Given this list of marker genes CACNA1D, HNF1A, OCA2, TMEM67, OTC, MPL (NCBI Gene Id 4352), SOX11, DNASE1, CDKN2C, HTT, ROS1, VAMP1, TNFAIP3, PLA2G6, INSR, IL12A, RFX7, LARP7, NLRP3, EZH2, LUZP1, AVPR2 (NCBI Gene Id 554, arginine vasopressin receptor 2), FIP1L1, POMC, CDC73, HESX1, IL23R, PTPN22, SYT2, ADNP, BLK, GLA, SRRM2, DZIP1L, IFT74, CDK13, PCSK1, SNAP25, SMARCB1 (NCBI Gene Id 6598), ABCC8, MN1, PACS1, FCGR2B, MC2R, KL, CD3D, PDCD1, PRKCZ, SYK, SIM1, SH2B1, SLC41A1, AVP, SATB2, CISD2, IL6, TNIP1, BRCA1, SLC1A3, NUMA1 (nuclear mitotic apparatus protein 1), SLC3A1, ATP1A3, KIAA0319L, OTX2, SLC4A1, SNORD115-1, MAPT, ERAP1, LEPR, SUPT16H, TXNRD2, MYT1L, KLRC4, PALB2, BRAF, TAF4, STAR, HLA-DRB1, YY1, CLDN16, PGM2L1, SOX3, IL10, GRN, AGPAT2, HLCS, SNRPN, ALPL, STAT3, SLC5A7, NTRK2, SMARCD1, CASR, SMARCC2, NKX2-1, MC4R, MEFV, COL13A1, KCNJ10, PAX4, STAT5B, SYNGAP1 (synaptic Ras GTPase activating protein 1), IRF2BP2, ATM, GPR101, CALR, NNT, RNU4-2, PWRN1, MAGEL2, IRF4, SPEN, NPHP1, TNFSF4, MMP23B, DPF2, PROKR2, P4HA2, STAT4, SLC2A3 (solute carrier family 2 member 3), ARID1B, ASXL1, BRCA2, HLA-B, NEK8, SPP1, UBE3A, HMGCL, ARID1A, CTNNB1, BCOR, BSND (barttin CLCNK type accessory subunit beta), IGHG1, AGRN, MEN1, AQP2, ACBD6, RARA, C4B, CTLA4, FLI1 (NCBI Gene Id 2313), TBL1XR1, PRKAR1A, ATP5F1B, CLDN10, PKHD1, CHAT, ACAT1, CDKN2B, NEXMIF, SKI (NCBI Gene Id 6497), ZNF699, PTPN3, SCARB2, ZSWIM6, PWAR1, FAS, IL12B, GRB10, ATRX, ETS1, ELP2, CTNS, RERE, SLC5A2, ITPR3, IFNGR1, TGFB1, HSD11B2, PALLD, GABRD, IRF5, ZBTB16, SMARCE1, SMARCA4, TLR4, ITGAM, PSEN1, NPM1, HSPG2, PDSS1, CASZ1, PML, TLR7, PREPL, SOX4, JAK2, SRSF2 (serine and arginine rich splicing factor 2), MAN1B1, BBS2, IRAK1, NAGS, UBAC2, CDKN1B, SLC46A1, PDPN, SLC12A3, ADCY3, ALMS1, WFS1, MEIS2, SMAD4, ASH1L (ASH1 like histone lysine methyltransferase), SLC25A1, TRANK1, CR2, KRAS, CRELD1, MLX, SNORD116-1, NABP1, SLC39A4, IL12A-AS1, CYP11B1, ZFX, CLCNKB, KCNAB2, NPHP3, SLC7A7, MECP2, BBS9, ARG1, UCP2, GNAS, MYD88, HPSE2, SLC18A3, GBA1, BSCL2, ATP10A, KCNJ1, RUNX1, MRAP, NPHP4, PXK, MMADHC, HERC2, CACNA1A, DPYD, SLC19A2, UBE2L3, DCDC2, NPAP1, FGFR1, MBD5, LZTFL1, TREX1, MKRN3, MYO9A (NCBI Gene Id 80251), TP53, DHPS, SLC25A13, CD3E, PRDM16, CYP11B2, CHD8, OFD1, BANK1, RABL3, KCNJ5, CDKN1A, ARID2, CCR1, NFS1, UBE4B, JAZF1, ARNT2, ATP1A2, CBL, KCNJ11, PCDH19, C4A, FCGR3B, DNM1, SCN4A, SOX2, CD247, CDKN2A, NDN, MMUT, HNF1B, LRIG2, LEP, CCND1, SETD2, CBS, TET2, here is a description of the gene set: Human Gene Set: HP_ABNORMAL_CONSUMPTION_BEHAVIOR Recurrent abnormal consumption of food, liquids, or objects that could have negative consequences for the individual. Abnormal consumption behavior species: Homo sapiens